The following is a description of a gene set: Binding to a SMAD signaling protein. studied in species Mus musculus Mouse Gene Set: GOMF_SMAD_BINDING, and this is the list of marker genes: Fermt2, Cited1, Rgcc, Men1, Tgfbr3, Zbtb7a, Ski, Stub1, Tgif1, Tob1, Bmpr1a, Usp9x, Pparg, Prdm16, Flna, Smad7, Zmiz1, Arap1, Axin1, Acvr1c, Skor1, Smurf1, Dab2, Col1a2, Pax6, Zeb2, Acvr1b, Ankrd1, Drosha, Acvr1, Tgfb1i1, Rnf111, Parp1 (poly (ADP-ribose) polymerase family, member 1), Bmpr1b, Tcf12, Creb3l1, Ipo7, Foxa2, Snw1, Foxh1, Usp15, Ranbp3l, Skil, Ctnnb1, Myocd, Ranbp3, Cited2, Acvrl1, Zc3h3, Crebbp, Fkbp1a, Trim33, Ddx5, Purb, Col3a1, Tgfbr2, Ppm1a, Fos, Ep300, Zfyve9, Tgfbr1, Pmepa1, Smad2, Pura, Mef2a, Col5a2, Jun, Tgfbrap1, Yy1 (YY1 transcription factor), Smad1, Hipk2, Ldlrad4, Smad3, Smad9, Hmga2, Gata4 (NCBI Gene Id 14463), Smad4, Pml, Smad6, Magi2, Skor2, Axin2, Eid2, Smurf2, Smad5